The following is a description of a gene set: Genes having at least one occurrence of the motif NNNNCAAGNRNN in the regions spanning 4 kb centered on their transcription starting sites. This matches the TITF1 transcription factor binding site V$TTF1_Q6 (v7.4 TRANSFAC). studied in species Homo sapiens Human Gene Set: TTF1_Q6, and this is the list of marker genes: GLI1, PSTPIP1, ELAVL4 (ELAV like RNA binding protein 4), SLC38A3, LINC00649, CNOT2, NCDN, KRCC1, DOCK7, CACNG2, PHYHD1, ZNF485, SLC20A1, AQP4-AS1, EIF2AK3, THBS1, TPM2, OGFOD1, GCAT, SERPINB5, BNC2, JARID2 (NCBI Gene Id 3720), HOXA13, CCNG2, CORO1A, FOXP2, CACNA2D3, ZIC1, AQP4, PITPNC1, WDR3, HEXIM2, ELK4, HTN1, TMEM187, CRK, TXNDC12, CYTH3, HOXD8 (homeobox D8), FZD7, CAP1, BRD2, ABLIM1, ERH, C14orf119, MLEC, SNRPA, ADNP, GDAP2, HOXA10, PCDHGC3, NRG2, ZMYND8, PIP4K2C, ZBTB37, TRPM3, ESR1, IMPG1, ZNF532, SYT17, IL17F, RSRC1, WDR13, PGF, ALG12, CCR9, CITED1, C6orf15, BABAM2, MYOCD (myocardin), DCTN1, SLC39A9, SCRT2, MYC, H1-0, PHKG1, TEAD1, BMI1, ZNF804A, HOXC6, TRPV6, PRR14L, MYL1, ACTMAP, NABP2, H3-3B, PIK3R3 (phosphoinositide-3-kinase regulatory subunit 3), NPPA, WBP1, TKFC, CRTAC1, CLDN15, IGF2BP3, WASF2, CDC42EP3, STK32C, RREB1, CCDC107, ATP10B, WNT8B, LRRN2, BMP2, AKAP9, CREB1 (cAMP responsive element binding protein 1), RPL10L, ICA1, LRRTM3, PICALM, COLCA1, CDCA7L, HHIP, MAP2K5, ADGRB2, RINT1, AMIGO3, OVOL2, CRH, MAFB, ZFYVE27, CDX2, TENM3-AS1 (TENM3 antisense RNA 1), NTN3, HPCAL4, FLT1, BLCAP, CNTN1, CAVIN1, STC2, EPB41L4B, ROR1, PCDHAC2, MAP4, FBXW4, PPTC7, AP4S1 (NCBI Gene Id 11154, adaptor related protein complex 4 subunit sigma 1), PTK7, OBI1, GPM6A, LIF, SLC6A7, CLUH, FOXN3, TMEM88, PRSS35, ADCYAP1, TUBAL3, MAP2K1, DLC1, DMP1, GJC2, SRCIN1, CHD4, TREX2, HNRNPA0, MIR9-1HG, RSKR, MAZ, DRD2, PELI3, KCNH2, GFPT2 (NCBI Gene Id 9945), WDR53, ARX, TRRAP, IFT43, IGF2R, WNT3, RBKS, ERN1, ELF4, PRDM8, SLC35A2, DENND2D, DUSP14, AK9, TUG1, FAM167B, FBXL19, B3GAT3, COL5A3, BMP4, GPR27, CLMN, SMARCA1, ASB2, CRELD2, RAG2, KCNK18, MTRFR, SLC25A3, ATN1, CDK5, SDF2L1, FEZF2, SCARF1, NKX2-1, CFL2, PLXNB1, KLF5, TCF4, SPEG, HPCAL1, TWIST1, CDIN1, RPS6KA4, NDRG2, UST, RBM26, GRIK5, FAM193B, HESX1, CLC, RAB27A, ZNF513, ZNF654, SOX14, TAF15, FAM83H (family with sequence similarity 83 member H), HOXC4, ZNF521, C15orf32 (NCBI Gene Id 145858), EMSY, RYR1, HIGD1B (HIG1 hypoxia inducible domain family member 1B), MXI1, ATP8B2, DLX1, PCDH17, FGF17, LHX6, DLGAP4, PTBP2, BPIFB6, PCSK1, HOXB5, CPNE1, CD101, LZTS2, ADCY6, PTPRT, SPACA6, MFSD5, TEC, CNIH2, WNT7B, HOXB6, PPFIBP1, CNTN6, ZIC4, NOVA1, STRN3, SLC4A2, HEBP2, EZH2, C6orf62, ACIN1, EIF4E, ZP1, DAB2IP, SPRY4, PDHA2, RCOR2, KLF7, CD248, CDX4, DDB1, SYTL2, HERPUD2